The following is a description of a gene set: from publication Durante MA, Kurtenbach S, Sargi ZB, Harbour JW, Choi R, Kurtenbach S, Goss GM, Matsunami H, Goldstein BJ (PMID 32066986) Human Gene Set: DURANTE_ADULT_OLFACTORY_NEUROEPITHELIUM_CD4_T_CELLS species: Homo sapiens, and this is the list of marker genes: IL7R, FYB1, CD69, PTPRC, STK4, GMFG, HCST, TNFAIP3, CD3G, CD2, CORO1A, ACAP1, TAGAP, CD3E, TRBC2, CD3D (NCBI Gene Id 915), RORA, TRBC1, GPR183, ARHGDIB, CD52, TSC22D3, LTB, CXCR4, RPS29, CLEC2D, TRAC, IL32, CD48, KLRB1